Given this list of marker genes Sfr1, Ap5b1, Apaf1, Tmem41b, Tnks2, Lnpep (NCBI Gene Id 66485), Col2a1, Gm27003, Cyb5r4, Ggt5, 9330136K24Rik, Stk10, Wdr90, Ccng1, Mix23 (mitochondrial matrix import factor 23), Rexo2, Anapc13, Cep63, Fam168a, mt-Ti, Nop14, Det1, Mdm4, Plekha1, Itgal, 1810062O18Rik, H2ac22, Lsm3, Pomp, Hilpda, St8sia1, mt-Ty, Zfp456, Prkx, Pierce1, Pmaip1, Jade2 (NCBI Gene Id 76901), mt-Te (mitochondrially encoded tRNA glutamic acid), Slc2a9, 4930522L14Rik, Trim32, Vwa1 (NCBI Gene Id 330009), Arhgap30, Plekha2 (pleckstrin homology domain-containing, family A (phosphoinositide binding specific) member 2), Rcc2 (NCBI Gene Id 72534), H2bc22, Mxd4, Xpc, Gabpb1, H3f3b, Ube2e2, Tiam1 (T cell lymphoma invasion and metastasis 1), Msmo1, Snord60, Dnm3, mt-Tl2, Pop7, Cmah, Wdfy2, Micall1, Serpine1, Parp11, Dcaf4, Qki, 4930412F09Rik, Ugt1a6a, Fam162a, mt-Co1, Laptm4a, Eif4a1, Zfp91, Pa2g4, Plekhb2, Fbxo34, Letm1, Fam53a, Rcc1, Tmem229b, Gm9530, Chst15, Kri1, Cd47, Eed, Pfdn6, Il2rb, Gne (NCBI Gene Id 69688), Orm3, Fdxacb1, Mknk2, Cd151, Zcchc9, Prim1, Fam219b, Hras, Smad3, Slc30a5, Wnt10b, Rrbp1, Hyal1, Inpp5b, Isy1, Gnpat, Lmna, Ptpn22, Pard3, Tut4, Gpn3, Icam1, Gm15564, Sfi1, Scn4b, Cdkn2aipnl, mt-Nd6, Cd70, Aldh4a1, Lrrc56, Atrip, Rb1, Cxcr5, Birc3, Gm19353, Macf1, Snora73a, Snhg3, Zmiz2, Slc7a5, Sms, Ppil3, Pidd1 (p53 induced death domain protein 1), Sec24a, Rgs1, Rab21, Traf3ip2, Ipmk, Ndufa12-ps, Rnpep, Mir6236, Gpr132, Cops9, Wdpcp, Cep128, Pdia3, Gm4890, Rnf123, Slc37a2, Gm6410, Mitd1, mt-Tl1, Rpl36al, Sdad1, Gm15408, Kbtbd7, mt-Tw, mt-Th, Cyth1, Emd, Anln, Cish, Ezr (ezrin), Dis3l, Tax1bp1, mt-Ta (NCBI Gene Id 17726), Gna15, Sh2b3, Gm1720, 2810021J22Rik, Mitf, Rassf5, Saysd1, Cdc14a, Gm22863, Cbarp, Lsm4, Zfp1007, Nif3l1, mt-Nd1, Mfsd4b3-ps, Gpx1, Park7, Mtmr4, Gm17057, mt-Nd5, Midn, Podnl1, Pcmt1, Gm9903, Gm29040, Birc6, Gm26479, Ecd, Tnk2, Gm15471 (predicted gene 15471), Gm8357, Agpat5, Vamp4, Tpt1, Mdm2, BC048644, Astl, Aaas, mt-Td, Mid1, Spmip2, C5ar2, Mark4, Rps19, Egln1, mt-Cytb, Gm16008, Arhgap11a (NCBI Gene Id 228482), mt-Tm, Apobec1, Gm26535, Tigd5, Kcnn4 (potassium intermediate/small conductance calcium-activated channel, subfamily N, member 4), Tnpo2, Ppp2r1b, Creld2, Sass6, Elk4, Mir8098, Rps27l, Mgat2, Tmem95, Junos, Gm11714, mt-Tt, Ifih1, Tmem267, Gm16315, Zfp850, Tatdn2, Bbc3, Gm10392, Gm17382, Ptpa, Cd80, Zscan25, Txlna (NCBI Gene Id 70304), Ugt1a6b, Egfros (NCBI Gene Id 319954), mt-Tn, Mir205, Adamtsl5, Arhgap23, E230029C05Rik, Sh2b2, Glipr1, Smg9, Map3k8, Fbxw11, Stat1 (NCBI Gene Id 98183), Mthfd1, Mrpl30, Calhm2, Sarnp, Gde1, Sh2d1a, Coil, 2610307P16Rik (RIKEN cDNA 2610307P16 gene), Zfp429, Trbv31, Ikbip, 1700022E09Rik, Mst1, D330041H03Rik, mt-Nd2, Cdk17, Rin1, Mir3091, Atp5f1d, Gpd2, Msh6, Foxn3, Mapkapk3, Tm7sf2, Clic1, Rac1, Gm13546, Ei24, Mindy2, Gclm, Traf7, Gm23205, Phlda3, Fam193a, Syne2, Soat2, Adrb2, mt-Tv, Duoxa1, Trp53cor1, Ugt1a7c, Isl2, Smarcc2, Lrrc28, mt-Tq, mt-Tc (NCBI Gene Id 17727), Alg12, Adcy3, Thap12, Acad8, Fam216a, Morc3, Fabp5, Jak3, Gm4285, Mbd6, Pltp, Rps21, Wdr46, Pold3, Zbtb25, Cfap68 (NCBI Gene Id 93817), AU040972, Fam107b, Traf3ip3 (TRAF3 interacting protein 3), Plagl2, Incenp, Bin2, Zfp750, Inpp5d, Cdkl3, Gm26631, Zfp263, Dhrs3, Zbtb1, Rab26os, Aida, 3110070M22Rik, Pvt1, Gm57488, mt-Ts2, Fam149b, Nktr, Pacs1 (phosphofurin acidic cluster sorting protein 1), Duxf1, mt-Rnr2, 1700064M15Rik, Orm1, Ogt, mt-Co2, Elp6, Fas, Ercc4, Madd, Catsper2 (NCBI Gene Id 212670), Eef1d, Thyn1, Syne3, Dusp6, Sh2d2a, Trp53inp1, G530011O06Rikx, Tex2, Ormdl2, here is a description of the gene set: Mouse Gene Set: TRP73_TARGET_GENES studied in species Mus musculus from publication Yevshin I, Sharipov R, Kolmykov S, Kondrakhin Y, Kolpakov F (PMID 30445619) Genes containing one or more binding sites for (Trp73) in their promoter regions (TSS -1000,+100 bp) as identified by GTRD version 20.06 ChIP-seq harmonization.